Given this list of marker genes CXCL8, CCL4, PLEK, HLA-DQA2 (NCBI Gene Id 3118), THBS1, TMEM176A, ICAM1, NAMPT, SAMSN1, RNF144B, TNF, NLRP3, NFKBIZ, CXCL2, BCL2A1, CCL3, NFKBIA, IL1B, G0S2, SOD2, CXCL3, CD83, ACSL1, CCL4L2, TNFAIP3, GNLY, TMEM176B, here is a description of the gene set: species: Homo sapiens Thirty-eight PBMC samples from 25 patients with IPF and 13 matched controls yielded 149,564 cells that segregated into 23 subpopulations. Classical monocytes were increased in progressive and stable IPF compared to controls (32.1%, 25.2%, 17.9%, respectively, p<0.05). Total lymphocytes were decreased in IPF vs controls, and in progressive vs stable IPF (52.6% vs 62.6%, p=0.035). Tregs were increased in progressive vs stable IPF (1.8% vs 1.1% of all PBMC, p=0.007), although not different than controls, and may be associated with decreased survival (P=0.009 in Kaplan-Meier analysis; P=0.069 after adjusting for age, sex, and baseline FVC). Flow cytometry analysis confirmed this finding in an independent cohort of IPF patients. Fraction of Tregs out of all T cells was also increased in two cohorts of lung scRNA-seq. CCL22 and CCL18, ligands for CCR4 and CCR8 Treg chemotaxis receptors, were increased in IPF. The single-cell atlas of the peripheral immune system in IPF, reveals an outcome-predictive increase in classical monocytes and Tregs, as well as evidence for a lung-blood immune recruitment axis involving CCL7 (for classical monocytes) and CCL18/CCL22 (for Tregs). (From Abstract) from publication Unterman A, Zhao AY, Neumark N, Schupp JC, Ahangari F, Cosme C Jr, Sharma P, Flint J, Stein Y, Ryu C, Ishikawa G, Sumida TS, Gomez JL, Herazo-Maya JD, Dela Cruz CS, Herzog EL, Kaminski N (PMID 38717443) Human Gene Set: UNTERMAN_PROGRESSIVE_VS_STABLE_IPF_MONOCYTE_DN Genes downregulated in Monocytes from Progressive Idiopathic Pulmonary Fibrosis Patients vs. Stable Non-Progressors